Given this list of marker genes Npas4, Arnt, Maged1, Bmal1, Arnt2, here is a description of the gene set: Transcriptional Regulation by NPAS4 Mouse Gene Set: REACTOME_TRANSCRIPTIONAL_REGULATION_BY_NPAS4 studied in species Mus musculus